The following is a description of a gene set: electronically inferred by orthology from the curated human pathway Reactome Pathway: Retinoid metabolism and transport species: Mus musculus This event has been computationally inferred from an event that has been demonstrated in another species.<p>The inference is based on the homology mapping from PANTHER. Briefly, reactions for which all involved PhysicalEntities (in input, output and catalyst) have a mapped orthologue/paralogue (for complexes at least 75% of components must have a mapping) are inferred to the other species. part of: Metabolism of fat-soluble vitamins; Visual phototransduction, and this is the list of marker genes: Apoa2, Lrp8 (NCBI Gene Id 16975), Akr1b10, Apoa4, Akr1c21, Bco1, Rbp2, Sdc1, Rbp4, Lrp12, Gpc2, Pnlip, Gpc3, Sdc3, Akr1c6, Bco2, Akr1c20, Lpl, Apoc3, Akr1c14, Apoe, Akr1c18, Lrp10, Gpihbp1 (NCBI Gene Id 68453), Apob, Apoa1, Apoc2, Akr1c13, Rbp1, Lrp1